The following is a description of a gene set: Binding to a LIM domain (for Lin-11 Isl-1 Mec-3) of a protein, a domain with seven conserved cysteine residues and a histidine, that binds two zinc ions and acts as an interface for protein-protein interactions. Human Gene Set: GOMF_LIM_DOMAIN_BINDING studied in species Homo sapiens, and this is the list of marker genes: TLN1, ACTN2, ISL1, LDB2, KAT14, LDB1, RIPK2